Given this list of marker genes DECR2, HERC4 (HECT and RLD domain containing E3 ubiquitin protein ligase 4), LARGE1, ALKBH5, MITF, GNPAT, THUMPD1, MKRN1, SSBP3, S1PR1, LINC00324, MYO1F, ASRGL1, ENSG00000289161, ACP5, STAC3, KDM3B, IFIT2, ZRSR2, KDM5D, ZFP91, RTN3, SYNE1, UFL1, SLFN11, PTPA, CHST12, KAT8, MCOLN1, XPO1, DNAAF11, SLC15A2, SWAP70, CBL, AP2A2, SPTBN1, ERMP1, CYTIP, SPTAN1, CNRIP1, DOCK11, NABP2, TUT7, HACE1, DUSP22, RFXAP, TARBP1, IL1R1, PPIL3, CORO1C, PFKFB4, SPAG16, TPI1 (triosephosphate isomerase 1), TACC3, OR52K3P, NUDT13, SULT1A1, FMO5, PGM2, PROSER2-AS1, WDR54, HACD2, ZNF467, MLKL, PRSS35, GOPC, SIPA1L3, PUS10 (NCBI Gene Id 150962), CAB39, CFL2, PAN3, RALGPS2 (NCBI Gene Id 55103, Ral GEF with PH domain and SH3 binding motif 2), STT3B, ZNF615, CBX4, SLC44A1, COX11, EGLN1, PPP2R5C, KDM3A, SELL, CERS2, ZSCAN16, RAB11FIP1, PTPN4, ABCC5, RPS6KB2, UBXN11, CALHM2, IGF1R, SNRK, KAT2B, DCAF5, SUMO3 (NCBI Gene Id 6612, small ubiquitin like modifier 3), AP1S2, THEM6, FAM76B, SLC47A1 (NCBI Gene Id 55244), NDRG3, DBP, HFE, STN1, MTCL2, PLPP6, KPTN, PDE2A, MYCBP2, STK38, IQCH-AS1, ITSN1 (intersectin 1), WDR81 (NCBI Gene Id 780925), SLC7A8, GNG7, RFPL1S, TRAM1, SOAT1, MPST, APMAP, ATP2B4, SRD5A1, FBXO41, TAS2R10, WIPI1, RNF170, WDR91, ZNF823, SLC2A13, LINC02481, RAD51AP1, SUMO2, EPS8, TRIM52 (tripartite motif containing 52), BDH2, M1AP, CTDSP1, MCU, FCHO2, EPHB2, ARL15, BLOC1S6, SRPK2, AP3S2, PCMTD2, DSG2, PIPOX, ARGLU1, CEP68, ST6GAL1, CACNA2D4, DPYD, PLA2G15, H2BC8 (H2B clustered histone 8), ERP27, INSR, GOLPH3L, CSTPP1, UROD, ASGR2, ROGDI, ZNF571, EID1, MGST2, NAGLU, PCM1, NUP214, ADORA3, ZNF117, VEZF1, CMPK1, JHY, ANO6, ZNF251, HSBP1L1, HAPSTR1, CCDC88A, TBC1D24, TCF19, RFX3, ZC3H6, EDEM2, ATP6V0A1, GCHFR, ZNF19, JMJD1C, EPRS1, DOP1A, NUDT16L2P (NCBI Gene Id 152195), NR1D2 (NCBI Gene Id 9975), ATP11A, CAMLG, MRM2, CREB5, RAB7B, KDM5B, CD99, MRTFB (myocardin related transcription factor B), SPPL3, here is a description of the gene set: Gene expression analysis of freshly isolated CD14+ human monocytes and monocytes cultured in the presence or absence of interferon (IFN) -gamma for 24 h and then stimulated with Pam3Cys, a Toll-like receptor (TLR) 2 ligand, for 6 h. Results provide insight into mechanisms by which IFN-gamma reprograms early macrophage differentiation and subsequent response to TLR ligands. Human Gene Set: GSE11864_CSF1_VS_CSF1_PAM3CYS_IN_MAC_UP Genes up-regulated in comparison of macrophages cultured with M-CSF versus macrophages cultured with M-CSF and Pam3Cyc. from publication Hu X, Chung AY, Wu I, Foldi J, Chen J, Ji JD, Tateya T, Kang YJ, Han J, Gessler M, Kageyama R, Ivashkiv LB (PMID 18976936) species: Homo sapiens